Given this list of marker genes BAX, PCNA, RBL2 (RB transcriptional corepressor like 2), CARM1, TP53, PRMT1, AURKA, TFDP2, E2F4, EP300, ZNF385A (NCBI Gene Id 25946), TFDP1, CDC25C, CDK1, RBL1, GADD45A, SFN, CCNB1, here is a description of the gene set: TP53 Regulates Transcription of Genes Involved in G2 Cell Cycle Arrest species: Homo sapiens Human Gene Set: REACTOME_TP53_REGULATES_TRANSCRIPTION_OF_GENES_INVOLVED_IN_G2_CELL_CYCLE_ARREST